The following is a description of a gene set: Human Gene Set: CCAATNNSNNNGCG_UNKNOWN studied in species Homo sapiens from publication Xie X, Lu J, Kulbokas EJ, Golub TR, Mootha V, Lindblad-Toh K, Lander ES, Kellis M (PMID 15735639) Genes having at least one occurrence of the highly conserved motif M104 CCAATNNSNNNGCG in the regions spanning 4 kb centered on their transcription starting sites. The motif does not match any known transcription factor binding site. Comprehensive identification of all functional elements encoded in the human genome is a fundamental need in biomedical research. Here, we present a comparative analysis of the human, mouse, rat and dog genomes to create a systematic catalogue of common regulatory motifs in promoters and 3' untranslated regions (3' UTRs). The promoter analysis yields 174 candidate motifs, including most previously known transcription-factor binding sites and 105 new motifs. The 3'-UTR analysis yields 106 motifs likely to be involved in post-transcriptional regulation. Nearly one-half are associated with microRNAs (miRNAs), leading to the discovery of many new miRNA genes and their likely target genes. Our results suggest that previous estimates of the number of human miRNA genes were low, and that miRNAs regulate at least 20% of human genes. The overall results provide a systematic view of gene regulation in the human, which will be refined as additional mammalian genomes become available., and this is the list of marker genes: ARX, CHAC1, NCK1, SOX2, MRPS18B, SAP130 (NCBI Gene Id 79595), UTP18, DMAC2L, ZDHHC5, H1-2 (NCBI Gene Id 3006), PIK3IP1 (NCBI Gene Id 113791), APC2, PEX2, EN1 (NCBI Gene Id 2019), L2HGDH, STX5, ETV1, DHCR24, POU3F3, EDEM1, LHX2, PAX6, TES, PSRC1, TMPO, IL6ST, RCL1, GPX3, SQLE, MEIS1, MEF2C, FAR1, ASXL2, FAM193B, TLE3, SMAD2, KHSRP, XPO1 (exportin 1), ST8SIA1, PPP1R10, ARL6IP6, LMAN1, NKX3-1, HES1, SREBF2, CDK2AP2, PCNA, CREBRF, THAP5, CLSPN, DNAJB9, SMAD6, ELAVL3, ACACA, AIFM1, UPF3B, PDP1, RAD9A, PNRC1, HOXA9